The following is a description of a gene set: Defects in beta-galactosidase (GLB1; MIM:611458) can result in GM1 gangliosidosis (GM1; MIM:230500) (not described here), with several phenotypes indicating mental deterioration, as well as in mucopolysaccharidosis IVB, a characteristic mucopolysaccharidosis with no neurological symptoms.<br><br>Mucopolysaccharidosis IVB (MPS IVB, Morquio's syndrome B; MIM:253010) is a rare, autosomal recessive mucopolysaccharide storage disease characterized by intracellular accumulation of keratan sulfate (KS), skeletal dysplasia and corneal clouding. There is no central nervous system involvement, intelligence is normal and there is increased KS excretion in urine (Suzuki et al. "Beta-galactosidase deficiency (beta-galactosidosis): GM1 gangliosidosis and Morquio B disease", p3775-3809 in Stryer et al. 2001). MPSIVB is caused by a defect in betagalactosidase (GLB1), which normally cleaves terminal galactosyl residues from glycosaminoglycans, gangliosides and glycoproteins. The GLB1 gene spans 62.5 kb and contains 16 exons (Oshima et al.1988, Santamaria et al. 2007) and maps to chromosome 3p21.33 (Takano & Yamanouchi 1993). part of: Mucopolysaccharidoses studied in species Homo sapiens Reactome Pathway: MPS IV - Morquio syndrome B (CS/DS degradation), and this is the list of marker genes: GLB1